Given this list of marker genes THSD7B, TMPRSS2, PLEKHA8 (NCBI Gene Id 84725), SAMD12, POPDC2, ABI2, OBI1, TGFBR1, ZMYM4, SEMA7A, CPSF2, CNTNAP4, SARM1, STRA6, FIGNL2, RGS6 (regulator of G protein signaling 6), DOHH, ERBB2, NFAM1, MS4A14, RPTN, LOXHD1, MAP3K14, CPLX2, CDC42EP4, ZNF609, DYNC2I1, DCLRE1B, PTPN7, DHTKD1, MRRF, PHLPP1, KSR1, SOCS1, FBLN7, ZNF37A, PML, PTPN2, DUSP5, TSPAN18, C2CD4C, SLAMF9, XPO7, NBEA (NCBI Gene Id 55091), BAIAP2, ZNF652, CASK (calcium/calmodulin dependent serine protein kinase), EARS2, RIMS4, APBA1, AP2A1, CDCP2, UBL3, HS6ST2, ARHGEF37, SPOP, PPP2R5B, GRIK3, RALA (NCBI Gene Id 5898), RECQL5, NRP2, PANK2, ZBTB2, here is a description of the gene set: Genes predicted to be targets of miRBase v22 microRNA hsa-miR-331-3p in miRDB v6.0 with MirTarget v4 prediction scores > 80 (high confidence targets). Human Gene Set: MIR331_3P from publication Chen Y, Wang X (PMID 31504780) studied in species Homo sapiens